The following is a description of a gene set: INTRODUCTION: Molecular characterization of the normal epithelial cell types that reside in the mammary gland is an important step toward understanding pathways that regulate self-renewal, lineage commitment, and differentiation along the hierarchy. Here we determined the gene expression signatures of four distinct subpopulations isolated from the mouse mammary gland. The epithelial cell signatures were used to interrogate mouse models of mammary tumorigenesis and to compare with their normal human counterpart subsets to identify conserved genes and networks.METHODS: RNA was prepared from freshly sorted mouse mammary cell subpopulations (mammary stem cell (MaSC)-enriched, committed luminal progenitor, mature luminal and stromal cell) and used for gene expression profiling analysis on the Illumina platform. Gene signatures were derived and compared with those previously reported for the analogous normal human mammary cell subpopulations. The mouse and human epithelial subset signatures were then subjected to Ingenuity Pathway Analysis (IPA) to identify conserved pathways.RESULTS: The four mouse mammary cell subpopulations exhibited distinct gene signatures. Comparison of these signatures with the molecular profiles of different mouse models of mammary tumorigenesis revealed that tumors arising in MMTV-Wnt-1 and p53-/- mice were enriched for MaSC-subset genes, whereas the gene profiles of MMTV-Neu and MMTV-PyMT tumors were most concordant with the luminal progenitor cell signature. Comparison of the mouse mammary epithelial cell signatures with their human counterparts revealed substantial conservation of genes, whereas IPA highlighted a number of conserved pathways in the three epithelial subsets.CONCLUSIONS: The conservation of genes and pathways across species further validates the use of the mouse as a model to study mammary gland development and highlights pathways that are likely to govern cell-fate decisions and differentiation. It is noteworthy that many of the conserved genes in the MaSC population have been considered as epithelial-mesenchymal transition (EMT) signature genes. Therefore, the expression of these genes in tumor cells may reflect basal epithelial cell characteristics and not necessarily cells that have undergone an EMT. Comparative analyses of normal mouse epithelial subsets with murine tumor models have implicated distinct cell types in contributing to tumorigenesis in the different models. Human Gene Set: LIM_MAMMARY_LUMINAL_MATURE_DN from publication Lim E, Wu D, Pal B, Bouras T, Asselin-Labat ML, Vaillant F, Yagita H, Lindeman GJ, Smyth GK, Visvader JE (PMID 20346151) studied in species Mus musculus Genes consistently down-regulated in mature mammary luminal cells both in mouse and human species., and this is the list of marker genes: PCF11, PRICKLE1, NREP, COL6A1, ZNF521, SORBS1, C1QBP, HEY2, PDZRN3, LMO4, GPX7, CRYAB, EGFR, FAM171A1, JAG2, NTRK2, SERPINH1, B4GALT6, CAMK2D, RASA3, DAB2, AQP9, FAM13A, MOB3B, VIM, SOX10, RASL12, TPST1, FRMD4A, CYRIA, FOXO1, FZD1 (NCBI Gene Id 8321), STAC2, CASP1, LAMA1, NFIB, TIAM2, TSPAN2, BACE2, IRS2, TUBB6, APOE, FAS, IRX1, CCL2, ABTB3, DPYSL2, LRIG3, WTIP, TFAP2C, ETS1, GAS6, MEIS2, TMEM47, FABP5, MAP4K4, COL4A2, NRTN, COL16A1, GYPC, COL6A2, CALD1, AEBP1, FAM181B, LTBP4, SLC6A15, BCL11A, RECK, IGFBP3, COL4A1, TGFBR3, MOXD1, HTRA1, TLE4, MERTK, FOXN3, TINAGL1, FBXO32, PALM2AKAP2, AXIN2, P3H2, NES, KCTD12 (NCBI Gene Id 80710), ITPKB, C2orf88, CYGB, SPARCL1, RAP2B, LPL, EPB41L2, SFRP1, SLC1A3, TSHZ2, SNAI2, FSTL1